Given this list of marker genes PHPT1, ACER2, F5, AEN, GADD45A, MGME1, TNFSF4, ASCC3, JADE3 (jade family PHD finger 3), TRIAP1, AMZ2, OR2G6, CCDC90B, CCNG1, GLS2, RINL, ASTN2 (NCBI Gene Id 23245), ITPR2, SPATA18, FAS, SLC7A6, E2F7, BRMS1L, EI24, TMEM30A, FGF10, CDS2, APOBEC3C, MAMDC4, RETSAT, PCNP, HECTD3, BBC3, SESN1, PPP4R3A, OR2T11, ANKRA2, DDB2, NDUFAF6, CPSF3, PYHIN1, NSF, BAX, INKA2, DENND2D, PCNA, TM7SF3, ZNF337, LIG1, DNER, H3C6, MAP4K4, CMBL, ANXA4, DCP1B (decapping mRNA 1B), PRKAB1, PPM1D, GCSAM, CD70, RRM2B (ribonucleotide reductase regulatory TP53 inducible subunit M2B), RAP2B, PTGER1, ISCU, RPL22P19, PTP4A1P7, POLR2A, FDXR, FGD3 (NCBI Gene Id 89846), PAPPA-AS1, TRIM22, TIGAR, RNU6-1156P, TP53INP1, TMEM68, PLK2, TMEM131, BLOC1S2, PVT1, MDM2, IRAG2, FBXO22, PTP4A1 (NCBI Gene Id 7803), EDA2R, MIR34AHG, REV3L, XPC, RNA5SP354, ZNF79, TNFSF8, CDKN1A (NCBI Gene Id 1026), TMT1A, ZMAT3, SOCS4, TNFRSF10D, IKBIP, TCAIM, POLH, APOBEC3H, TNFRSF10B, NSD1, PANK1, OR2T2, TRIM32, RPS27L, ACTA2, ARHGEF3, here is a description of the gene set: Peripheral blood mononuclear cells (PBMC) were isolated using Histopaque-1077 (Sigma-Aldrich) from 10 healthy donors (5 males, 5 females, aged 23-50). Isolated cells were resuspended at a density of 106 cells/ml and allowed to equilibrate to culture conditions at 37°C in a humidified 5% CO2 atmosphere. PBMCs were then exposed to 0 (sham), 0.1 or 1.0 Gy of X-rays (250 keV - 1 mA, 1 mm Cu) at a dose rate of 0.26 Gy/min. After irradiation, cells were incubated at 37°C in a humidified 5% CO2 atmosphere for 8 h before RNA extraction. Two weeks later, the experiment was repeated using fresh PBMCs from the same donors, resulting in a total of 60 RNA samples. Total RNA (250 ng) was used for hybridization to GeneChip Human Gene 1.0 ST arrays (Affymetrix). This gene set contains genes that were up-regulated after radiation exposure (3-way ANOVA, FDR <0.05). studied in species Homo sapiens Genes up-regulated in human peripheral blood mononuclear cells (PBMC) at 8 h after exposure to 0.1 and 1.0 Gy dose of ionizing radiation. from publication Macaeva E, Saeys Y, Tabury K, Janssen A, Michaux A, Benotmane MA, De Vos WH, Baatout S, Quintens R (PMID 26763932) Human Gene Set: MACAEVA_PBMC_RESPONSE_TO_IR